Given this list of marker genes Bmp4, Gdf11, Dll1, Pdpk1, Mir7-1, Mir375, Cftr, Wnt5a, Clock, Onecut1 (one cut domain, family member 1), Rfx6, Mir214, Bad, Pax4, Bhlha15, Nkx6-1, Bmal1, Insm1, Vhl, Cdk6, Bmp5, Mir541, Rheb, Ier3ip1, Smo, Sidt2, Gata6, Cdh2, Bmp6, Nkx2-2, Men1, Mir503, Pax6, Reg1, Rfx3, Pdx1, here is a description of the gene set: The process in which relatively unspecialized cells acquire specialized structural and/or functional features of a type B pancreatic cell. A type B pancreatic cell is a cell located towards center of the islets of Langerhans that secretes insulin. studied in species Mus musculus Mouse Gene Set: GOBP_TYPE_B_PANCREATIC_CELL_DIFFERENTIATION